The following is a description of a gene set: studied in species Mus musculus Mouse Gene Set: chr16C4, and this is the list of marker genes: Gm31641, Lca5l, Kcnj6, Gm41495, 1700093J21Rik, Kcne2, Mx1, Gm15340, 2410124H12Rik, 1600002D24Rik, Ttc3, C2cd2, Fam3b, Vps26c, Gm32358, Setd4, Gm31323, Sim2, Mir802, Ripk4, Gm49641, Mrps6, Fam243, 1700029J03Rik, Gm32432 (predicted gene, 32432), B3galt5, Cbr1, Dyrk1a, Gm30881, Gm23692, Cryzl1, Smim34, Morc3 (microrchidia 3), Smim11, 1810044K17Rik, Gm29880, Gm41505, Pcp4, Cbr1b, Erg, Slc5a3, Itsn1, Mir6964, 2310043M15Rik, 1700048M11Rik (NCBI Gene Id 73386), Donson, Mx2, Gm9242, Gm32509, D430001F17Rik, Hlcs, Gm15310, Gm6363, Gm46555, Psmg1, A630089N07Rik, Rcan1, Runx1, B230307C23Rik, Clic6, Sh3bgr, Atp5po, Chaf1b, Kcne1, 2810404F17Rik, Prdm15, Gm26626, Gm10785, Tmprss2, Gm6599, Dop1b, Gm29805, Gm23355, Ets2, Zbtb21, Gm15342, 2210009P08Rik, Kcnj15, Brwd1, Pigp, Gm18020, Bace2, Hmgn1, C030010L15Rik, Ripply3, Gm41504, Get1, Dscam, Cbr3, Gm23210, 1810053B23Rik, Itgb2l, Gm49723, Cldn14, Gm41496, Igsf5, 2410003I16Rik